Given this list of marker genes Egr2, Sgk1, here is a description of the gene set: part of: Nuclear Events (kinase and transcription factor activation) species: Mus musculus electronically inferred by orthology from the curated human pathway This event has been computationally inferred from an event that has been demonstrated in another species.<p>The inference is based on the homology mapping from PANTHER. Briefly, reactions for which all involved PhysicalEntities (in input, output and catalyst) have a mapped orthologue/paralogue (for complexes at least 75% of components must have a mapping) are inferred to the other species. Reactome Pathway: NGF-stimulated transcription